The following is a description of a gene set: Human Gene Set: KEGG_MEDICUS_VARIANT_MUTATION_CAUSED_ABERRANT_HTT_TO_AUTOPHAGY_VESICLE_NUCLEATION Pathway Definition from KEGG: HTT* -| (BECN1+PIK3C3+ATG14+PIK3R4+AMBRA1) Mutation-caused aberrant Htt to autophagy-vesicle nucleation. Pathway ID: N00993. Pathway type: Variant. Pathway class: nt06461 Huntington disease. species: Homo sapiens, and this is the list of marker genes: HTT, BECN1, ATG14, PIK3R4, PIK3C3, AMBRA1